The following is a description of a gene set: Human Gene Set: REACTOME_GLUCAGON_LIKE_PEPTIDE_1_GLP1_REGULATES_INSULIN_SECRETION studied in species Homo sapiens Glucagon-like Peptide-1 (GLP1) regulates insulin secretion, and this is the list of marker genes: ITPR3, IQGAP1, GNG7, KCNC2, GNG13, ADCY8, GNB5, GNB2, GNG12, GNB1, GNG11, KCNG2, GNB3, RAPGEF3, PRKACB, ITPR1, GCG, GNG10, RAPGEF4, GNAS, KCNS3, PRKAR2A, GNB4, ADCY5, GLP1R, RAP1A, GNG8, GNG2, PRKAR1A, KCNB1, PRKAR1B, PRKAR2B, GNGT2, GNGT1, ADCY6, AKAP5, GNG5, ITPR2, PRKACG, PRKACA, GNG4, GNG3